The following is a description of a gene set: Human Gene Set: MIR6895_3P Genes predicted to be targets of miRBase v22 microRNA hsa-miR-6895-3p in miRDB v6.0 with MirTarget v4 prediction scores > 80 (high confidence targets). from publication Chen Y, Wang X (PMID 31504780) studied in species Homo sapiens, and this is the list of marker genes: SLC7A7, ZNF208, XPNPEP3, CHMP7, ZNF625, LPP, CHST9, AXIN2, SH2D1A, HRH3 (histamine receptor H3), MLANA, SUGP2, AMMECR1, SORBS1, ACER2, KCNIP1, MOXD1, TIMM17A, TTC39B, A1CF, DOK6, COL22A1, C2orf49, NUAK1, STON2, ERG, PALM2AKAP2, FGF20, SON, TIMP3, SPINK13, PPP2CA, CHCHD3, PPIG, EEIG2, CPLX2, ADAMTS3, EPB41L1, CTSO, SLC38A1 (solute carrier family 38 member 1), DLG2, ARCN1 (archain 1), SMYD4, DRAM2, DNAJC3, F7, DDR2, BAMBI, ABO, RANBP17, ZNF676, MXI1, DENND6A, TRIM37, MED23, FUT8, NHLH2, OSTF1, ECM2, NTM, TMPRSS11A, ZNF638, ASXL2, TCAIM, SERTAD1, LRRC39, ZNF343, CUTC, INO80 (NCBI Gene Id 84156), CASK, SBF2, PRDM16, OSBPL11, CHTOP, HLA-A, SH3PXD2A, TMEM248, SLC4A1AP, AFTPH, MCC, ASIC1, CACNG8, MBD1, TRIP13, NYAP2, KLHL14 (NCBI Gene Id 57565), MPZL3, HLA-G, PURA, RAB8B